Given this list of marker genes SDHC, THRAP3, DIP2C, GUCY2C, NDNF, LARP1B, MSTN, SLITRK6, TOB1, ARMT1, USP46, SP4, BDNF, CACNA2D3, EGF (epidermal growth factor), RIT2, SOX13, NKX6-1, CFHR3, STIM1, WDR81, LSR, ROGDI, EVX1, CSRNP3, PHKA1, CALM1, MAF, ERF, AXIN2, ATXN1, RNF19B, GPR61, PYM1, HES1, PDE1A, AP1AR, RFC1, SDC4, GFRA1, DAB1, TNIP3, SSH2, ABCB5, ESR1 (estrogen receptor 1), GC, PIAS2, HOXA7, HES7, TRMT13 (tRNA methyltransferase 13 homolog), RNF182, FEZF2 (FEZ family zinc finger 2), SCN8A, CCDC88A, CABP7 (NCBI Gene Id 164633), U2AF1L4, TBK1, PRSS35, FZD7, KLF6, TOX2, NRG1 (NCBI Gene Id 653104), ZFHX4, NFIB, MYH10, PRUNE2 (prune homolog 2 with BCH domain), COLEC10, CPT1A, CLVS1, NAP1L5, PIP4K2A, NXF3, CA10, THBS1, IGSF21, SSR1, KCNN2, BASP1, TCF4, CACNA1D, CPEB2, ELOVL4, ASB4, MYL1, HOXB4, EOMES, ERLIN1, MTCH2, OXR1, RMND5A, AQP1, SLC24A4, GABRA1, ZDHHC5, RHOB (NCBI Gene Id 388), LAPTM4B, PLIN1, DOP1A, LDB2, PLCB1, MAFA, OSBPL6, H3-3A, GPX1, SOBP (sine oculis binding protein homolog), USP12, EIF2S2, HMGN2, ZNF768, SPRY1 (NCBI Gene Id 91129), CCDC181, ZNF202, CUL3, CHD2, TXLNGY, TOM1L2, RNF38, TMEM35A, SCAI, CDK12, NXF1, HOXA6, INTS9, VEZF1, NECTIN1, CPNE4, ACAN, AFF3, MECOM, GPR65, DUS4L, PDIA4, ADAMTS2, APP, SH3BP5, MRPS6, TFPT, CRP, SETD7, HNRNPR, EMCN, MAML3, SCRT2, KCTD9, ITGA1, DACT1, TEAD1, CPNE9, LAMB2, TCF7L1, SLC13A4, YPEL4 (yippee like 4), MARCHF3, TRIM8, LRR1, NIPBL, USP25, NOL4L, IL18R1, CACUL1, TMEM182, TRMT9B, SOX14, IL1RAPL2, TRPC4, KCNK12, TUBB2B (NCBI Gene Id 347733), TSC1, LIN37, UAP1, SLC4A2 (NCBI Gene Id 96677), PABPC1, WNT2, MEIS1, EXT1, CNTNAP5, TRDN, FGFR1OP2, URI1, TSPAN2, KLF12, SOX9, TP53, ARL14EP, HOXC5, PABIR1, AVPR1B (arginine vasopressin receptor 1B), NEUROD1, TGM4, NEBL (nebulette), CA13, C1orf198, HOXD10, VCL, NR2E1, AAK1, KCNS3, HOXB2, BRS3, LINC03124, NPHP4, RBP2, HIPK1, ATXN7L1, DSCAML1, ACTB, TAFA1, SAP30L, FCGRT, DLL1, RHOBTB1, BASP1-AS1, INO80D, HOOK1, SCARA5, SEZ6L, KPNA6, GNG4, GRIK1, KRTAP22-1, SFSWAP, FRMD5 (FERM domain containing 5), NCOA3, EIF5, SLC30A7, CACNB3, NSD1, ARID1A, ELMO1, SLC26A7, ATP2B4, IMPA2, GPBP1, TMEFF2, MYT1, DDIT3, GIGYF2, ANK3, AKIRIN2, DDX3X, KDM3B, SNTB2, PPP2R2A, BCOR, ACVR1C, TSEN54, DMRT2, SOX6, PLAG1, SMAD2, SIRT6, FGF12, PRKAR2B, BTBD3, COL1A2 (NCBI Gene Id 1278), CLDN8, BTLA, NPC2, ZNF436, EIF1AY, TCF12, NFKB2, PLAGL1, DNAJA1, RXFP1, PHEX, CRH, FGF14, LRRC8D (NCBI Gene Id 55144), DLG2, MFSD14A, SMAD5, SOX3 (NCBI Gene Id 8256), PRPF38B, MDGA1, SPIB, TEAD2, CCDC22, ZNF280C, TAFAZZIN, WASF2, PHF8, SUMO4 (NCBI Gene Id 387082), ACSBG1, LRRTM4, SLC4A7, SEMA3F, RIC3, RNF13, TAFA4 (NCBI Gene Id 494553), UBR3, HCN1, KLHL32, SLC6A11, ELF4, ETF1, SESN2, STARD13, NCOA5, TMEM132E-DT, ENAH, ZBTB20, ARID3B, MELK, WBP4, SIX3, SEMA5A, TRPC5, AGPAT4, NPAS2, BCL11B, CALM3, BCL9L, SEPHS1 (selenophosphate synthetase 1), NHS, CREB1, EPHA7, PFN1, RAP2A, MYCL, RUNX1, GARIN2, ADAMTS9, NRSN2, WBP1L, HOXA3, OSBPL9, B3GLCT, KMT5A, TAF10, SFXN5, PUM3, CNKSR2 (NCBI Gene Id 22866), TFAP2D, SORBS1, C1QTNF7, FGF16, ARHGEF11 (NCBI Gene Id 9826), SCN1A, ZNF521 (zinc finger protein 521), RYBP, SAP130, MTSS1, CDKL5, ZIC5, GLS, XYLT2, RPL34-DT, CHST11, NR1D1, TMSB15A, ZDHHC22, ASTN1, MOS, SLK, CALN1, HSPH1, CNTNAP2, MYO18A, PELO, PSME3IP1, BCS1L, TENM3-AS1, CDCA7, AMMECR1L, MYOD1, DRC3, SEL1L, LRRC1, CDH11, UST, STEAP4, LEF1, LRMDA, FMR1, RAB30, TNFRSF19, SEMA6A, SDF2, ASB5, PRKAB2, CBX8, FOXN3, PRP4K, PPP1R12A, FBXO2, PRKAA2, CALB1, SYTL2, JARID2, LAMA4, ANXA11, GALNT14, TMEM196, EFNB3, SCAF8 (SR-related CTD associated factor 8), NUP54, CAPN6, ELAVL2, HOXC10, GABARAP, IL21, TAF2, CHD6, EFHC2 (NCBI Gene Id 80258), DUSP10, ALCAM, ST8SIA2, PDPN, CHRDL1, ITIH2, CTNNA3, SH3D21 (SH3 domain containing 21), DDX17, TMEM74B, CCDC80, PLCB3 (NCBI Gene Id 5331), MIR17HG, UTY, LHX2, HOXC12, PIK3R1, RELN, AMDHD2, SLC16A14, FOXO3, RANGAP1, PRDM12, UBE2O, PLPPR1, DYRK1A, LARGE1, TMEM38A, PYGO1, ZIC1, CACNA1F, SLC22A12, FOXB1, RARB, PRNP, RBPMS, KRAS, ORC4, PRKACB, NCDN, EVC2, PALS2, GPR37, TTC17, NELL1, CACNA1G (calcium voltage-gated channel subunit alpha1 G), STAU1, TEF, PCM1, IRF1, RNF145, ARL4A, TMTC2, USB1, CYTH3, MBD6, CCDC71L, ROR1, LETM2, ZCCHC3, LUZP1, DHRS3, TMEM107, C9orf85, GAREM1, SPATA31H1, DYNC1I1, ALK, GPC3, SLC39A13, CEPT1, PPM1E, KCMF1, TOM1, MECP2, ABHD17B, BTG1, HCN4, LASP1, CFHR5, GRHL2, PMF1, CDK2AP1, ZDHHC9, TMEM52, LHX6, MCF2, NFE2L1, RND2, CDH1, NMT1 (N-myristoyltransferase 1), NR6A1, PLPP3, PLXDC2, ANGPT2, CACNB2, PGRMC1, DACH1, EIF2B4, GPC6, FABP4, PNOC, LTBP1, CD34, SLCO3A1, MED12, LCOR, TSPAN7, GK, COL19A1, ZBTB3, ACBD5, CASKIN2, CMIP, DIP2B, EDEM3, VIM, PURA, CCNC, POC1B, ADNP, TRPS1, MRPL47, LOX, PSENEN, HS3ST3B1, SEMA3A, SPART, FDX2, ARL5B, PPME1, ZEB2, UGP2, TNPO2, DGKI, SLITRK1, SLC2A12, HOXA10, CNTN1, NR4A2, IRAG1, GLDC, EHBP1, OSR1, CUL1, RABGAP1L, CREM, TENT5C, MGLL, PRKCI, VSTM2L, SRSF2, GNB4, MRFAP1, SDCBP, TAFA2, SLC5A3, UBE2R2, GASK1B, KDM6A, ZIC4, PDGFB, ARMCX3, PCF11, PLXNC1, TLE1, AUTS2, NOL4, PRPF31, RPS6KA3, MPP2, LRP1, CDIN1, ZBTB37, SPTSSB, NDST3 (NCBI Gene Id 9348), PHOX2B (NCBI Gene Id 8929), ZNF362, SPG21, RAD23A, ENTR1, SCAF4, VCAN, PYGO2, ADCY6, FAM81A, ST6GALNAC3, KRT10-AS1, CEP290, JADE3, CHRNA6 (NCBI Gene Id 8973), UQCRFS1, EEF1DP3, MBNL1, F2RL1, MOXD1, SPTB, PDE4D, GNAS, ST18, PAX6, MAN1A2, SRSF6, MCU, CTBP2, FOS, SLC10A2, NEUROD6, DOCK4, VSTM2A, TAOK3, TRAF3, VSX2, ADCY2, KANK2, FAM91A1, ATL2, MMP16, ATP8A2, GABRB1, MERTK, SOX2, PSMA8, DEPDC7, DDX46, COL13A1, SHC1, ARHGEF17, RIT1, SMARCA2, XBP1 (X-box binding protein 1), POU3F4, SREBF2 (sterol regulatory element binding transcription factor 2), NLGN1, ZNF792, SOCS2, NFKBIA, PDYN, CBLN4, TLK2, CHST8, IL16, FLI1, RBFOX1, MRPS31, NRXN1, ACKR3, SPRY2, SNX1, NOX3, LHX1, ERO1A, SERPIND1, KLF4, MIR22HG, TFAP4, INTS13, HOXB7, BBS12, STK32B, KIF3B, UTP18, PLEKHA8 (NCBI Gene Id 84725), MYLIP, XPO7, NCKAP5, CDK5, GNAI1, TNFSF18, ARPC2, NDST4, TENT4B, PROX1, EPYC, BHLHE40, PTCH1, TDP1, ATP11C, ABCA12, NR3C1, CA12, ELMO2, RAB6C (NCBI Gene Id 84084), SOX21, LMNA, STAC, ANKRD13B, SIX5, RBMX, PARP6, NETO1, TYRO3, MED12L, BEGAIN, IGF2R, OTP, FBXL5, FOSB, ATL3, SETD2, INVS, MYOZ2, INF2, IMPDH2, ABCC5 (NCBI Gene Id 10057), EGLN3, MAPK3, UBE2F, RAPGEF4, IGF2BP1, CEACAM20, ZFAND6, RTL9, ADAMTS6, SNW1, DCSTAMP, POU2F1, ADGRB2, DOCK3 (NCBI Gene Id 1795), SOX5, CGRRF1, SH3BGRL3, ID2, HOXC11, SCN4B, KMT2C, FANCB, PRELID2, CDH13, FAM20B (FAM20B glycosaminoglycan xylosylkinase), STC1, PALS1, PAIP1, RCOR2, LDLRAD3, ZNF322, DGKH, SKIDA1, WWP2, FOXD3, LHFPL3, NEUROG1, PARD3, PHF21B, CD72, STC2, MLLT10, MSX2, GOLPH3L, CELF3, LRP1B, GRHL3, GABRA3, TECTA, SLC12A2, CACNG3, SMPX, CTNND1, RAB3C, NUAK2, OLFM1, TMEM87A, CYLD (NCBI Gene Id 8010), EPHB1, ENPP2, EIF4EBP2, NOS1 (nitric oxide synthase 1), MAP3K3, DAAM2, TMEM229B, ZC2HC1C, GPR22, NCAM2 (NCBI Gene Id 4685), PCDH9, CTNNB1, SPSB2, MRTFA, INPPL1, PFKFB1, PIAS1, LDAH, NXPH4, CHN1, ATXN7L2, ITSN1, DLK1, EFNA4, SLITRK5, NCALD, ARF3, GRIA3, ZEB1, H1-0, UVRAG, LAMP5, OTUD7B, THOC6, RGMA, HS2ST1, TMEM145, SLC22A11, EPHA5, GSS, CCNB2, NFATC4, ARHGAP36, PPP1R1B, NR2F2, MAP2K6, FILIP1, LSAMP, LRRFIP2, RSRC2, PCDH11Y, TMEM243, NSD2, ZBTB18, HOXA2, ING4, PPP1R17, DNMT3A, PID1, KCNG3, TIMP3, PRDM13, USO1, SH3BP4, IL11, CPNE5, NOVA1, GATA1, ZNF516-DT, CSNK1A1L, ARHGEF2, DHX40, PCSK5, CBX7, SLC2A10, ARVCF, NDUFA11, BARHL2, PHACTR3, FYCO1, SSBP3, RASA4, ZNF431, KCNJ13, PRSS12, CRYGC, PAX2, SP7 (Sp7 transcription factor), GFPT2, LRRN1, TPBG, DNAJA2, SLC6A15, CAMK1D, IL6ST, BTRC, HOXA11, SLC25A28, SALL1, RAP1B, AMOTL1, STAC2, REST, DOCK8-AS1, IRF2BPL, DAAM1, ZFAND3, FAM13C, ADCY8, PSMD11, CDH10, ADGRD1, CCNJL, ADAM23, PITX3, ADM, IL1RAPL1, KRT18P55, PTBP2, PFN2, SEC24B, EYA4, CISH, WDR53, BLCAP, SIAH3, PATZ1, PIK3R3, FBXW7, SERPINH1, POU4F1, RABGAP1, MBNL2 (NCBI Gene Id 55479), PLA2G4B, TNFAIP8L1, ALDH1A1, P2RY10, CADPS, TLX3, FST, XPO4, VLDLR, BCAP31, KCND3 (NCBI Gene Id 3752), YRDC, PTK2, KCNIP4, HOXA1 (NCBI Gene Id 3198), HAO1, CASZ1, LUC7L, CRB3, ZNF804B, LURAP1L, ACSS2, SRRM4, CHST1, GPR85, APPBP2, CADM1, COL3A1, GLG1, RNF144B, CSMD3, TSC22D1, BHLHE22, C21orf91, KCNE2, DDX3Y, TNFRSF21, KMT2D, FAM78A, OVOL2, EIF3J (eukaryotic translation initiation factor 3 subunit J), ERBB4, HBP1, GPC4, AJUBA, PRPF3, MBOAT2, TMEM47, ZBTB2, PCDHGC3 (NCBI Gene Id 94378), LMX1A, HDGF, PPARGC1A (PPARG coactivator 1 alpha), VIPR2, GNA13, SNX17, SPAG9 (sperm associated antigen 9), PCDH8, SHC3, DIABLO, IGSF6 (NCBI Gene Id 10261), TSPAN6, EMSY, MAP3K4, OTX1, ADAM17, HMBOX1, RPL34, RNF152, PAX9, NEK6, ITGB4, UTP4, EPN3, GABRG1, ARL3, GPR183, POU3F2 (POU class 3 homeobox 2), ARHGEF7, SSBP2, EBF2, ROCK2, ARRDC3, GPR63, ATF7, SPP1, ID3, ENSG00000291228, CXXC5, SFXN2, SLAIN1, SIDT1, EDA, ZNF800, TAB2, HOXA5, PHF13, MAPK11, TCF7L2, PPM1J, RFX5, IL10, IPO4, OR2W1, DDR2 (NCBI Gene Id 4921), PARP9, PCDH7, WRAP53, DPYSL3, GPHB5, WNT8B, BPTF, ADD3, PPP4R3A, GINM1, EGR2, STAG1, SLC2A4, GANC, SOX4, SORCS3, MDFI, APBB2, PTPRF, GCAT, MGST1 (NCBI Gene Id 4257), ZNF706, SATB1, HCRTR2, HTR2A, FAT1, ZNF710, SYT6, RGS3, OTX2, SUPT6H, NUP93, NSG2, TRHR, SLC22A5, XPO1, GMPPB, MRPL1, ENSG00000204117, TSHZ2 (NCBI Gene Id 7765), TMSB4XP1, ZNF462 (NCBI Gene Id 84452), CLEC1B, CLRN3, FAXDC2, NR4A3, CAVIN2, CDH7, MED13, STEAP2, CKS1B, ZNF174, CFHR2, CNTFR, PDZRN4, FGF13, GRID2, NKX2-1, KIFAP3, KLHL36, SLC9A1, FLRT3, BTF3P11, HSPB1, PTMA (prothymosin alpha), HRH3, PRR15, RSPO2, DEDD, TXLNG, TP63, SOAT1, SRPX2, RORA, PRRX1, DOCK11, NFAT5 (NCBI Gene Id 10725), GCG, CACNB1, ST8SIA1, VIT, DCAKD, LAMP2, ZC3HC1, CAPS (calcyphosine), MIDEAS, TLK1, POU3F3, ING3, KLHL3, RBMS1, GYPC, SPARC, ETV6, ZMAT4, MITF, IRF2BP1, EIF1AX, IL9 (interleukin 9), ATF3, PPARD, WNT3, MMP24, CFAP65, EPC1, NKX2-2, IGF1R, ETV1, TSKU, NDUFB5, UBE2A, ZNF277, ZDHHC21, LINC02915, FOXA1, HCFC1R1, PRDM1, TM2D2, STK3, CEP350, AGO2, SMOC1 (SPARC related modular calcium binding 1), RPS6KA2, NPSR1, NADK2 (NCBI Gene Id 133686, NAD kinase 2, mitochondrial), BLTP3A, POU3F1, MLF2, CCN1, KRT8P41, FIP1L1, RNF128, MYC, SERPINC1, ARAP2, PCDH18, CLCN3, FOXO4, AMY2B, TMSB4XP4, RTL3, PHF20, JAZF1, GYS2, GPR52, HTR2B, TAL1, KDM2A, ANGEL1, SUFU, PKD2L2, MACIR (macrophage immunometabolism regulator), R3HDM1 (NCBI Gene Id 23518), ONECUT2 (one cut homeobox 2), TAB3, STAG2, KCNJ8, TFAP2A, JPH1, NR2F1, ADAMTSL3, JAG1, ACTR3, ETV5, PHF6, GPRC5B, VNN2, ABCA10, FGFR2, HESX1 (HESX homeobox 1), BRINP3, HLX, PBX1, CSRNP1, MAB21L1, CFAP47, GEM, TRARG1, LARP4, CTDSP1, PSAT1, OLIG3, PREP, NETO2 (neuropilin and tolloid like 2), IMPDH1, SRBD1, JUN, NR2F6, NRK, DTX3L (deltex E3 ubiquitin ligase 3L), HYCC1, TLE4 (TLE family member 4, transcriptional corepressor), PITX2, BCL9, NHLH1, AMD1 (adenosylmethionine decarboxylase 1), KMT2A, PTPRK, AFF2, NUCB1, CA3, MAP1B, MEIS2, DLX1, AKT3, SKIL, SALL3, CDK18, CITED1, PRKD2, KAT6A, CCR1, RILPL1, PDS5B, OXCT1, TAC1, ANXA13, SCUBE2, TRAF2, KNTC1, DACH2, MLLT3, CFHR1, TNF, C14orf178, PHF21A, REPS2, KCNJ2, IRX4, ESRRG, SLC39A11, MAFB, AMIGO2, RUNX1T1, PAX7, CNTN6, RFXANK, SH3BGRL, ECT2, RBM14, RFX3 (NCBI Gene Id 5991), SHANK2, BNC2, PLCL1, DENND6A, TAF11, FAM53B, NPVF (NCBI Gene Id 64111), NVL, SPINK5, OR2S2, HCCS, DCN, ADAM9, DRD3, TCEAL8, LIX1, GRK2, ARRDC1-AS1, ADAMTS5, IFNB1, SHOX2, FRAS1, IER5L, SLC6A1, UBXN4, ARHGAP21, COL9A1, SLC4A10, SOX1, MEF2C, CUX1, CLSTN2, FZD5, PACSIN2, NCOA2, MYBPC1, RFTN2, P2RY13, HOMER1, NLK, TCP11, PMEPA1, ALDH6A1, CBFA2T3 (NCBI Gene Id 863), POSTN, TDRD3, ELAVL4, CDK17 (cyclin dependent kinase 17), WEE1, BTC, IRX5, CDK15, CDS1, VEGFA, NEUROD4, HOXB6, ZMYM4, AP1S2, SASS6, FGF10, EDIL3, JADE2, DGKD, EIF4E, CALB2, CDYL, JPT1, EIF4G1, CAMK2A, C6orf62, MMP13, ETV4, SNN, RREB1, ACOXL, TNNC1, ETNK2, VEGFD, MALL, ECHDC2, CACNG2, CYRIA, FUT9, OTUB1, SLC1A3, TSHR, MORF4, TPM3, HDAC4, ISYNA1 (inositol-3-phosphate synthase 1), CLEC18C, KCNQ4, SOCS1, ERBB2, CIB1, ITM2C, RFX4, CDC73, HNRNPUL1, RNF14, CELF4, SESN3, ZBTB16, MARCHF7 (membrane associated ring-CH-type finger 7), RBMS3, REPS1, ZFPM1, PLP1, PPARGC1B, KDM3A, ANKS1B, LRP8, TBXAS1, CHCHD7, CALD1, OTC, RAB11FIP5, FOXP2, ZFP36L2, BMI1, BCAR3, KITLG, ISL1, PTHLH, EIF3E, LUC7L2, ARSJ, CLIC4, CMTM4, RSPRY1, GALNT4, EPHX2, UBN1 (NCBI Gene Id 50641), RAB23, MACO1, PPFIA2, PGRMC2, GJA1, ACMSD, TGIF1, PTCHD1, PDCD5, NUDT4, PTGS2, TSC22D4, SNCAIP, ABCF2, IRS4, PDE7A, RAB1A, OSBPL7, HEMGN, MOSPD2, NEFM, GIT1, NBPF11, RAP2C, PIAS3, RTRAF, HRK, WASL, DARS1, TRPM3, IKZF2, ZNF219, DPF3, GPRIN3, ARHGAP44, LUC7L3, EFNA5, PRKCG, ZHX2, STEAP3, TOB2, KRT35, HOXB8, NFKBID, TTC23, ELK3, PRIMA1, SESN1, ZC3H18, SOX18, UBE2C, LCE1F, SERTAD4, ENO3, HPCAL1, CNTN4, BMF, COL4A6, QRFP, PLPP6, PICALM, MAGT1, CHID1, GHR, CDC14B, CYP26A1, NRAS, SAP30, VANGL1, KCNH8, MMD, OLFML3, ZNF827, CNTF, HDX, TRAF4, GPR50, ZIC3, DLGAP4, FARP1, SLC24A2, KDELR2, NPTXR, BCL6, STX1A, STK38L, FOXP3, CDH5 (cadherin 5), PTPRG, SZRD1, SDHAF3, BCL2A1, PGS1, KIT, MLN, LIN28A, CSF3, TMEM65 (NCBI Gene Id 286052), SPARCL1, PBX3, PROK2, NTN1, EED, SLC2A13, KCTD4, PPM1A, BMP1 (NCBI Gene Id 649), LDB1, EHF, GRIK3, TGFB3, CRYZL1, ILDR2, INHBA, PBXIP1, UBE2E1, RAP2B, GARNL3, SCUBE3, NTRK3, IFNLR1, SSTR3, SH3GL2, IGF1, LMO3, ARID1B, SLC16A6, LUM, TRIM2, CYP26B1, STX6, FGF23, HOXC4, SYT9, PPP2R2B, NKAIN3, ABHD4, GPRC5D, SGCD, HAPLN1, SLC24A3, G3BP1, CREBZF, IFT57, DCAF6, TNFSF10, LEAP2, BIRC6, TLE3, PPP4R2, LRRTM1, ADGRB3, NF2, PRRT2 (NCBI Gene Id 81865), ARF6, SPTBN2, MLEC, ARPP21, USP13, UBA3, RNF220, NLGN3, LRRC75A, UNC79, ABCD1 (NCBI Gene Id 215), TBC1D8B, PIKFYVE, MID1, U2AF2, NDP, BUB3, MB21D2, ZNF436-AS1, SH3KBP1, NAV3, NTNG2, HMGB1, PHYHIP, HSD17B14, CD69, HIF1A, LRP10, NPAS3, SLIT3, SHCBP1, MC3R, NPTX2, TIMP4, HSPG2, HEBP1, RALYL, MXI1, ANP32A, PCGF5, ING1, NRSN1, PDS5A, ADGRL2 (NCBI Gene Id 23266), ODAD2, HOXC8, TRIB1, PPP1R3B, SMYD2, NUCB2, PKIG, EIF5A2 (eukaryotic translation initiation factor 5A2), ADAMTSL1, CBLB, TGIF2, SI, CHP1 (calcineurin like EF-hand protein 1), NOTCH1, KCTD15, EYA1, ADRA1A, NR5A2, KIF5B, PCK2, HTR2C, ZFHX3, SELENOP, COL4A5, MYO1E, ZNF804A, MMP2, CPA2, GRIN3A, VAX1, LINC00472, HOMEZ, PTGFRN (NCBI Gene Id 5738), EGR3, REEP4, KRIT1, COG3, RAMP2, POU4F2, ZFPM2, PRDM16, JADE1, CPNE8, UBR4, CDK6, RALBP1, MIR9-1HG, EXTL2, HAT1, EMX2, PRMT3, HOXB9 (homeobox B9), SEL1L3, MN1, ATXN3, REL, TCERG1L, SCN5A, DMD, CDH9, CRHBP, CACNA1E, CTCF, TSPAN9, UCK2, ADRA1B, ANKRD36B, PITPNC1, SMAD6 (NCBI Gene Id 4091), SEMA4C, STK39, SERPINI1, PDE4B, ST6GALNAC5, HNF1A, ADGRF4, COPG2, RCAN2 (regulator of calcineurin 2), KANSL1, ACBD3, SENP6, TREM1, APBA1, CREB5, KCNJ3, PPRC1, LRATD2 (NCBI Gene Id 157638), EGFLAM, MAGI1, MPLKIP, PABIR2, PPP2R3A, KCNMA1, RRAGD, RNF122, STXBP6, CSNK2A2, OLA1, AZIN1, MIEF1, EHD4, MORF4L2, GRPR, CARTPT, NXPH1, STMN4 (stathmin 4), KANK4, HOXD4, PRKAG2, PDE9A, CABP1, CREBBP, SUMO2, FGFR1, MID2, FMNL1, ATOH1, ACSL4, FOXO1, PCYOX1L, PKHD1, CASQ2, KIZ, NRP2, MIR137HG, SIM1, IRX3, HS3ST4, PRPS1, LOXHD1, FOSL1, PDLIM3, RB1CC1, CRTAC1, MAP4K3, RYR3, FOXA2, TOP1, MRGPRF, ANKRD30BP2, SLC17A4, EIF2B5, LRRTM3 (leucine rich repeat transmembrane neuronal 3), CHN2, PLXNA2, HECTD2, FAM110D, MIPOL1, SEMA6D, MED25, BEND6, CDR2L, RAD21 (NCBI Gene Id 5885), JUP, HPSE2, CACNA1H, KCNIP1, SMAD1, RMND1, NELL2 (neural EGFL like 2), ERG, CRIM1, CHODL, MAPK10, PDE2A, COG5 (NCBI Gene Id 10466), BRWD3, CTNND2, ADGRV1, ITGBL1 (integrin subunit beta like 1), PPP2CB (NCBI Gene Id 5516), SERPING1, SCG2, BMPR2, COLEC12, FBXO44, SNTG1, SOSTDC1, RP2, CCN4, MYH1, DMRT3, UBR1, ADRB2, CD274, C11orf87, SNX27, BCHE, MSI2, IQGAP2, ENHO, HSD17B12, KYNU, LRRC3B, ARFGEF1, KIRREL3, ILRUN, KLF14, TBX5, BMP5, BCL11A, TRERF1, RIMS1, RILPL2, CORT, PWWP2B, SECISBP2, QRFPR, MPC2, PTH2R, CAMK2D, LZTS2, DTNA, TACR1, MEP1A, CCSER2, SELENOF, KLF8, PEX5L, ALX4, SNX21, PPP2R5B, ZBTB9, PRDX4, PRRX2, CDCA2, ZSCAN32, PCDH10, SLITRK2, RASSF2, SYNE1, HECTD4, GNB1, CLTA, HOXC6, NXPH3, PTEN, SUGCT, IKZF3, MANF, SPATA17, NKD1, MAST4, EPHB2, SLC26A3 (NCBI Gene Id 1811), HMGN5, COL27A1, TOMM22, CSNK2A1, GTF2E2, TTBK2, ANKS1A, HSD3B7, SYNE2, DZIP1, EFCAB11, DIS3L, ASB9, WNT7A, CP (ceruloplasmin), CIC, SPHK1, DIPK2A, GREB1, ABL1, SLC7A9, HOXB3, RORB, MBD5, SLITRK3, SRGAP1, CXXC4, TMEM132E (NCBI Gene Id 124842), DIAPH1, CRACDL (NCBI Gene Id 343990), PRICKLE1, CTSS, ISCA2, STAT3, ZFP36L1, GRM1, SNCA, NR3C2, SAMD1, DSPP, C1orf122, NOG, PDCD10, NMT2, RHOQ, SYNPR, SRSF1, SND1-IT1, PRRC2A, TRPC1, LRP6, TFDP2, GPATCH2, PHC2, EFNB2, LRRC2, SREBF1, ST3GAL2, WASHC4, FCHSD2 (NCBI Gene Id 9873), RAPGEF5, NFIA, PNPLA6, COMMD3, ST3GAL1, TIMM50, GCH1, ELOVL5, GRK6, FKBP4, HOXD3, TLR1, IRX6, KCNS2, SAV1, PCDH11X, TUBA1C, ACSF2, ATP7A (NCBI Gene Id 613259), SLC10A1, FGF9, UBE2L3 (ubiquitin conjugating enzyme E2 L3), RPS6KA5, SRC, UBE2E2 (NCBI Gene Id 7325), AXL, TMEFF1, MCHR1, EBF1, ATP5MC3, MREG, CREB3L2, GRM3, RCBTB2, RELCH, LNPEP, CYSLTR2, MEF2B, SREK1, PCSK1, CD40LG, ZBTB7B, EVA1C, COL25A1, CAMKV, here is a description of the gene set: Human Gene Set: AACTTT_UNKNOWN studied in species Homo sapiens Comprehensive identification of all functional elements encoded in the human genome is a fundamental need in biomedical research. Here, we present a comparative analysis of the human, mouse, rat and dog genomes to create a systematic catalogue of common regulatory motifs in promoters and 3' untranslated regions (3' UTRs). The promoter analysis yields 174 candidate motifs, including most previously known transcription-factor binding sites and 105 new motifs. The 3'-UTR analysis yields 106 motifs likely to be involved in post-transcriptional regulation. Nearly one-half are associated with microRNAs (miRNAs), leading to the discovery of many new miRNA genes and their likely target genes. Our results suggest that previous estimates of the number of human miRNA genes were low, and that miRNAs regulate at least 20% of human genes. The overall results provide a systematic view of gene regulation in the human, which will be refined as additional mammalian genomes become available. Genes having at least one occurrence of the highly conserved motif M17 AACTTT in the regions spanning 4 kb centered on their transcription starting sites. The motif does not match any known transcription factor binding site. from publication Xie X, Lu J, Kulbokas EJ, Golub TR, Mootha V, Lindblad-Toh K, Lander ES, Kellis M (PMID 15735639)